Given this list of marker genes ENG (NCBI Gene Id 2022), DGUOK, HMGCL, DRG1, PLA2G1B, EIF3F, RPL13A, RNASE6 (NCBI Gene Id 6039), RPL12, CD3D, ADSL, TTK, GLIPR1, RPLP1 (ribosomal protein lateral stalk subunit P1), CCL5, MRPL58, GRIA1, RPS21, S100A4, CRIP1 (cysteine rich protein 1), SLC25A20, MRPL3, RPS4Y1, KLRB1, CSTB, IL15RA, UQCR11, LIMCH1, TXNDC5, TRO, RPL19, FNTA, PEX7, PATJ, IGKC, ATP5PO, COL21A1, POLR2H, here is a description of the gene set: from publication Scherer CA, Magness CL, Steiger KV, Poitinger ND, Caputo CM, Miner DG, Winokur PL, Klinzman D, McKee J, Pilar C, Ward PA, Gillham MH, Haulman NJ, Stapleton JT, Iadonato SP (PMID 17651872) Human Gene Set: SCHERER_PBMC_APSV_WETVAX_AGE_18_32YO_2_TO_4DY_DN Gene expression in human peripheral blood mononuclear cells was systematically evaluated following smallpox and yellow fever vaccination, and naturally occurring upper respiratory infection (URI). All three infections were characterized by the induction of many interferon stimulated genes, as well as enhanced expression of genes involved in proteolysis and antigen presentation. Vaccinia infection was also characterized by a distinct expression signature composed of up-regulation of monocyte response genes, with repression of genes expressed by B and T-cells. In contrast, the yellow fever host response was characterized by a suppression of ribosomal and translation factors, distinguishing this infection from vaccinia and URI. No significant URI-specific signature was observed, perhaps reflecting greater heterogeneity in the study population and etiological agents. Taken together, these data suggest that specific host gene expression signatures may be identified that distinguish one or a small number of virus agents. Genes down-regulated in peripheral blood mononuclear cell (2 to 4)d vs 0d in adults (18-32) after exposure to APSV Wetvax, time point 2 to 4D species: Homo sapiens